The following is a description of a gene set: species: Homo sapiens Human Gene Set: WP_MEVALONATE_ARM_OF_CHOLESTEROL_BIOSYNTHESIS_PATHWAY Mevalonate arm of cholesterol biosynthesis pathway, and this is the list of marker genes: FDPS, IDI2, PMVK, IDI1, HMGCL, ACAT2, MVD, HMGCS1, FDFT1, GGPS1, MVK, HMGCR, ACAT1